Given this list of marker genes KYAT1, KYAT3, ALDH8A1, PRODH (NCBI Gene Id 9539), HOGA1, ABAT, ENSG00000274276, KYNU, CBS (NCBI Gene Id 875), DDO, ALDH5A1, BLMH, ALDH4A1, DAO, MTRR, SARDH, OTC, GOT2, AGXT2, here is a description of the gene set: The chemical reactions and pathways resulting in the breakdown of non-proteinogenic amino acids. Human Gene Set: GOBP_NON_PROTEINOGENIC_AMINO_ACID_CATABOLIC_PROCESS studied in species Homo sapiens